The following is a description of a gene set: species: Homo sapiens Human Gene Set: HP_PSEUDOEPIPHYSES Pseudoepiphyses, and this is the list of marker genes: GDF5 (NCBI Gene Id 8200), RPS6KA3, CPLX1, BMPR1B, MAP3K7, PTH1R, KCNH1, NKX3-2 (NK3 homeobox 2), COG4, HOXA13, NPR3, RAB23, CTBP1, ERI1, FGFRL1, PCNT, LETM1, NSD2, SALL1